Given this list of marker genes SELENOP, SMARCA1, DSG2, CX3CR1, ITGAV, TUBA1A, CD63, ENC1, EMP1, CLIC4, L1CAM, FGG, ANLN, CTSB, TUBB3, RAN, SERPINA3, PFN1, EDNRB, RAB1A, MMP2, TUBA3C, APLP2, TUBA4A, FZD1, RRAGA, LUM (lumican, NCBI Gene Id 4060), PRKCA, HMMR, SPA17 (sperm autoantigenic protein 17), MFAP1, SDCBP, SPARC, VCAN, CDH2, here is a description of the gene set: from publication Alonso SR, Tracey L, Ortiz P, Pérez-Gómez B, Palacios J, Pollán M, Linares J, Serrano S, Sáez-Castillo AI, Sánchez L, Pajares R, Sánchez-Aguilera A, Artiga MJ, Piris MA, Rodríguez-Peralto JL (PMID 17409456) EMT (epithelial-mesenchymal transition) genes up-regulated genes in melanoma tumous that developed metastatic disease compared to primary melanoma that did not. species: Homo sapiens Human Gene Set: ALONSO_METASTASIS_EMT_UP Metastatic disease is the primary cause of death in cutaneous malignant melanoma (CMM) patients. To understand the mechanisms of CMM metastasis and identify potential predictive markers, we analyzed gene-expression profiles of 34 vertical growth phase melanoma cases using cDNA microarrays. All patients had a minimum follow-up of 36 months. Twenty-one cases developed nodal metastatic disease and 13 did not. Comparison of gene expression profiling of metastatic and nonmetastatic melanoma cases identified genes with a >2-fold differential expression ratio and a false discovery rate of <0.2 (206 up-regulated and 37 down-regulated). This set of genes included molecules involved in cell cycle and apoptosis regulation, epithelial-mesenchymal transition (EMT), signal transduction, nucleic acid binding and transcription, protein synthesis and degradation, metabolism, and a specific group of melanoma- and neural-related proteins. Validation of these expression data in an independent series of melanomas using tissue microarrays confirmed that the expression of a set of proteins included in the EMT group (N-cadherin, osteopontin, and SPARC/osteonectin) were significantly associated with metastasis development. Our results suggest that EMT-related genes contribute to the promotion of the metastatic phenotype in primary CMM by supporting specific adhesive, invasive, and migratory properties. These data give a better understanding of the biology of this aggressive tumor and may provide new prognostic and patient stratification markers in addition to potential therapeutic targets.